Given this list of marker genes NIPBL, MPHOSPH9, RAVER2, ELL2, REV1, CDC42SE2, DDIT4, FGF17, INO80D (NCBI Gene Id 54891), KIAA0513 (KIAA0513), TNRC18, TMEM19, SAR1B, PLAG1, PRKX, TDRD5, SLC2A14, TRMT9B (NCBI Gene Id 57604), CTNND2, UBA52, MIB1, ITPR2, RAN, PPHLN1, WNK1, NDUFB6, SEPTIN8, MXRA7, AP1G1, MKS1, HMGCLL1, RBM20, PRRG1, ZNF704, CELF2 (CUGBP Elav-like family member 2), SMC5, CCDC126, CDKN1B, EFCAB5, MLLT3, HYCC2, ALG10B, DNER, FAM169A, PFKFB2, OCRL, NHLH2, MED12, SYT15, CSRNP3, PHLPP2, DDX3X, CBX5, SMAD9, MBLAC2, GRIA3, TULP4, CXCL2, CPSF2, AREL1, ANKRD26, SESN3, LRRC4, OR2L13, VPS13D, GAB1, PAQR9 (progestin and adipoQ receptor family member 9), NFYC, SENP6, ZNF318, ZFHX3, CDC6, TMEM39A, EXOSC8, GMFB (glia maturation factor beta), MTA3 (metastasis associated 1 family member 3), TNFRSF1B, SZRD1, IL1B, PGR, FAM184A, GPR180, SLX4IP, TM4SF1, UAP1L1, SEL1L, MFAP3L, PPP1CB, SCAI, NETO1, BDNF, AIFM2, UNC13C, PLCH1, HNF4G, RBM12, SHTN1, MED1, VTA1, PDE4D, TAF1, CAST, CD9, VDAC2, KCNJ13, GPR22, ROBO1, MLEC, TESMIN, GATA3, NTNG1, SPAST, FZD4, PICALM, KHDRBS3, CERT1 (NCBI Gene Id 10087), AKAP12, CDKN2B, IRAG2, ZNF599, RAPGEF6, SKIL, PABPC5, GSE1, MBTD1, KSR2, TMEM9B, PAIP2, STAT3, MDH1B, STK4 (serine/threonine kinase 4), ARHGAP28, SUCO, DNAL1, CADPS2, ZFHX4, UPB1, CDIN1, TEAD2, TIMM21, RC3H1, SLC44A5, NEURL1, INSIG1 (insulin induced gene 1), FGF14, NR6A1, HBEGF, PTCD3, GTF3C3, ACTA1, INTS6, CRIPT, RPRD1A, CSTF3, SLC30A7, TMX1, ALS2, KDM4A, NRXN1 (NCBI Gene Id 9378), RDH10, CBLL1, SLC35F2, CREBZF, TMEM170B, FOXO3, DCAF8L1, NT5C2, PDLIM5, SLC7A14, CAPS2, CHD6, FBXW7, CEP76, SPIN4 (NCBI Gene Id 139886), CCSER2 (NCBI Gene Id 54462), DDX52, HIGD1A, RBMS3, TM9SF3, ZNF281, SEPTIN11, SAMD12, SFMBT2, TMX3, PCNP, PHKG2, PPM1A, RAI2, SLC17A6, BCL11A, PPM1D, SCG2, PCLO, VEZF1, TNFRSF21, HCN1, UNG, ZNF362 (zinc finger protein 362), NCBP1, PCDH9, MS4A18, SPTSSB, R3HDM2, ANKRD13C, NEUROD6, PTPRJ, ABHD13, THSD7A, IGF1, ZNF264, CLDN10, ACTR10, SLC44A1, SEC62, KLHL8, PDE3A, PPP6C, TFDP1, GUCY1A2, C21orf91, ERCC6L2, PAPLN, ZNF592, FBRSL1, SLC35B4, EPCIP, ZBTB37, RGS17, PTPRE, MALL, PEX26, TPTEP2-CSNK1E, SREBF1, METTL4, RAET1E, NEBL, TLK2, SCN2A, DMRTC2, OSBPL8, PSME3 (NCBI Gene Id 10197), RICTOR, FNDC3A, GOLGA7, RMI1 (RecQ mediated genome instability 1), DEPDC5, TIGD6, ZMPSTE24, OTUD7B, MEF2A, NUP62CL, TTC6 (tetratricopeptide repeat domain 6, NCBI Gene Id 319089), TMEFF2, VGLL3, PGM2L1 (NCBI Gene Id 283209), ARPC1A, NR2F2, FEM1C, GAGE1, PHF1, PRPF38B, ZNF43, PPM1K, GPR63, AGBL4, HSP90AA1, ATP8A2, MECOM, EEF1E1, ONECUT2, CEP70, NAV1, SNX30, CAMTA1, TENT5A, WDTC1, ANKRD6, PRKAB2, DNAJC6, TRIM32, GTF2A1, POU3F1, CFAP92, MGAT2, NECTIN3, CNBP, ACBD7, RBM7, FAT3, POU2F1, PIAS2, SELENOI, PCM1 (NCBI Gene Id 5108), HTR2C, PNRC1, SAP18, RASGRF2, PTPN2, CSPP1, PTEN, ZNF804A, SATB2, LRP6, ELAPOR1, PELI1, GPM6A, B4GALT6, PLXNA4, ASTN2, AKAP11 (A-kinase anchoring protein 11, NCBI Gene Id 79988), SGCE, SLC16A10, ATXN7, SEC24A, PGAP1, KLF3 (NCBI Gene Id 51274), TESC, COL19A1, ZNF280D, GFI1 (growth factor independent 1 transcriptional repressor), HSPA5, MYEF2, CCDC88A, CNTNAP4, MID2, PRELID3B, ZRANB2, ZNF391, MET, BCAP29, KPNA2, HEY1 (hes related family bHLH transcription factor with YRPW motif 1), SLC6A15, RBPJ, MINDY2, PSMC6, NAALADL2, NLN, GRM7, SMNDC1, IER2, DPP8, ZNF234, FRMD4B, ERCC6, KCNH5, GPR158, MANEA (mannosidase endo-alpha), NPAP1, CPNE4, PPP1R2, NQO2, BCDIN3D, RALGDS, BMP7, SDC3, ZDHHC21, DDIAS, PPP4C, LHX2, MDM2, ST18, PCDH18, ZNF850, SHPRH, GLIS3, TAFA2, PHLPP1, CAMK2G, XYLT1 (NCBI Gene Id 64131), NUFIP2, ZBTB41, KLK10, PRDM9, ATP8A1, RORB, SOAT1, FAM91A1, AK5, PCDHB9, RUNX1T1, ITPK1, SFPQ, DNAH7, SMIM14 (small integral membrane protein 14), C3orf33, PPFIBP1, WIPF1, ZNF518A, CREBBP, HTR1E, MAPKBP1, SENP1, PRKAA2, ERI2, ASB7, PANK3, PRUNE2, NKAIN1, TMEM64, EZR, NACC2, PRR11, SOWAHC, AAK1 (NCBI Gene Id 652453), ZMYND11, PROM2, CYTH1 (NCBI Gene Id 9267), CMPK1, PCDH20, PHF13, LIFR, SEPTIN7, PRKD3, HDAC9, CAB39, CDK6, SAMD4A, PHF21A, NRXN3, CBFA2T2, AQP4, NCAM2, TDRD1, ELK4, ZNF273 (NCBI Gene Id 90816), NAPB, JUN, LNPK, MAST4, ATL2, AP4S1, SSX2IP, KIF13A, ILF2, USP15, PDHA1, MYNN, CACNA1D, PTPN13, QSER1, ZMYM5, PEX3, BMI1, SNRPB2, KMT2C, ZNF431, ARF6, NEXMIF, C5orf22, CLCN5, TNRC6A, HMGXB4, NDUFS2, NLGN1, MRPS10, CLIC4, MALT1, GAS1, MACROD2, PRTG, KHDRBS2, FNDC1, SH3BGRL2, MED12L, RPGRIP1L, NAT14, PEX2, CLEC6A, RPS6KA3, PBOV1, KAT2B, PLCXD3 (NCBI Gene Id 345557), JAZF1, PTK2, FOXP1, TMEM167A, ARHGAP5, VGLL4, TMEM268, TMED2, UNC5C, ANLN, PTPRA, NOTCH2, EPB41L3 (NCBI Gene Id 8730), RIMS4, RBM46, HTR1B, PHTF2, GPR155, ITGBL1, AKAP6, DNAAF5, DACT1, KIF1B, FAM133A, TMED9, KANK4, KMT2A, ZNF292, PBRM1, FCF1, NXPE3, STAT1, CERS6 (NCBI Gene Id 253782), CUL4B, NAA15, COPS7B, HSDL2, YTHDC1, CFAP44, PDE3B, GORAB (golgin, RAB6 interacting), DENND5B, CAND1, TCF4, FBXO28, ZNF548, RIMKLB, MAPK10, ATF1, KLHL15, SPEN, UBN2, TASOR, FKBP5, RRP1B (ribosomal RNA processing 1B), NUP62, BRINP1, TM9SF2, CADM1, ELAVL1, STK17A, CALU, ABCE1, PHC3, NAPG, PPIP5K2, DCUN1D3, RASSF9, NHLRC3, ENAH, ZNF280C, KDM2A, WASHC4, MEX3C, DNAJC3, GABRA1, LYPD6, THRB (thyroid hormone receptor beta), PASD1, MARCHF1, SLITRK2, CCSER1, ARRDC3, PPP4R3B, BPIFC, ZNF708, PDE11A, TBL1XR1, CA13, BNC2, U2SURP, CDON, S1PR3, MGRN1, UBE2D3, UTP23, ANTXR1, SHOX2, TMX4, CELF1, ETS2, PTK7, USP32, TMEM33, LRBA (LPS responsive beige-like anchor protein), TENM1, TNC, CARD6, ALCAM, HIPK1, ATP2B2 (ATPase plasma membrane Ca2+ transporting 2), MAOA, FKTN, DCAF17, FNDC3B, ITM2A, TEX261, APOL6, UBA6, SLC41A3, ZNRF2, TMEM47, EPB41L4B, NRBF2, UFM1, PKD1L1, CCNT2, CBFB, VPS35, FGF7, ZBED4, PDZD8, SNIP1, CPEB3, RASGEF1B, SESTD1 (SEC14 and spectrin domain containing 1), RLIM, TLE3, MPPED2 (NCBI Gene Id 744), PAF1, FIGNL2, EVI5, GOLPH3L, NAB2, PRR23C, ZMYM2, MSI2, CANX, CBX3, ELF1, CNOT6, G3BP1, SUPT16H, DICER1, CEP170, PMP22, SKIDA1, YOD1, ARK2N, NFATC2, TNKS (tankyrase), CDC37L1, STXBP5, RPRD1B, CDK14, NFAT5, GRWD1, F2RL2, KCMF1, PNISR, OTUD6B, NCF2, MTF2, TGIF2, FUT1, SULT2A1, HSPA2, RPRML, PRKAR1A, INPP4B, COL21A1, TRIQK (NCBI Gene Id 647518), RNF4, FGF5, HJURP, BACH2, PLEKHG1, SMIM7, TFAP4, PCYOX1, PHF6, AGFG1, ZNF280B, LAGE3, KDM5D, EEF2K, RLF, SNAP25, LCLAT1, DCUN1D4, PIK3CB, SCD5, TRIP11, CLOCK, ITGA4, BPNT2, ZFAND5, PDE12, STOX2, DMRT1, ZBTB20, ZFX, PRICKLE2, LAPTM4A, TGFB2, RAB18 (RAB18, member RAS oncogene family), LPGAT1, DCAF16, IL25, WBP1L, PRKAG2, PSAPL1, KLF5, DYNC1LI2, PDCL, DDX3Y, DUSP6, KLHL11, LRRTM4, CDC14A, NMT2, DDHD2, CPOX, WIPI2 (WD repeat domain, phosphoinositide interacting 2), NFIA (nuclear factor I A), UBE3A, HGF, GRK3, FGF2, BNIP2, EIF4G3, BCL2L1, ESM1, TP53INP1, ETS1, POGZ, GFPT1, FBXO30, ACTC1, FOXK1, OTUD4, LAMP2, MDC1, MYT1L, ZNF503, HIVEP2, SNRPD1, BCLAF1, LRRC25, NABP1, STK32B, ANKIB1, FUBP1, IDI1, NTN4, ZFR, DGKH, BROX, GPCPD1, SATB1, KLF8, P4HA2, NEK7, PPME1, TGFBR3, PAFAH1B1, SREK1, ASB5, SUMO1, TPD52L3, ARHGAP19, HOXA10, MINAR1, TRPC1, COL4A1, HESX1, SH3PXD2A, COPB1, FMN1, KCTD16, ATRN, SENP2, KIAA0232, ATF7IP2, CMTM4 (CKLF like MARVEL transmembrane domain containing 4), PRICKLE1, BUB1, CSNK1E, DENND1B, OPCML, IL6R, RHOU, PPP3CA, SCEL, CYP26B1, KCTD10, BAIAP2, HCCS (holocytochrome c synthase), TMEM41B, HOXC9, NFIB, MAPK9, COMMD3-BMI1, THBS2, here is a description of the gene set: from publication Chen Y, Wang X (PMID 31504780) studied in species Homo sapiens Genes predicted to be targets of miRBase v22 microRNA hsa-miR-5688 in miRDB v6.0 with MirTarget v4 prediction scores > 80 (high confidence targets). Human Gene Set: MIR5688